Given this list of marker genes DST, ZFHX2, ELP1 (NCBI Gene Id 8518), WNK1, CLTCL1, RETREG1, SCN9A, KIF1A, ALG11, NTRK1, NEUROG1, LIFR, here is a description of the gene set: Abnormal corneal reflex species: Homo sapiens An anomaly of the corneal reflex that normally induces involuntary blinking of the eyelids following contact of the cornea. Human Gene Set: HP_ABNORMAL_CORNEAL_REFLEX